The following is a description of a gene set: A change in the morphology or behavior of a leukocyte resulting from exposure to an activating factor such as a cellular or soluble ligand, leading to the initiation or perpetuation of an inflammatory response. Mouse Gene Set: GOBP_LEUKOCYTE_ACTIVATION_INVOLVED_IN_INFLAMMATORY_RESPONSE studied in species Mus musculus, and this is the list of marker genes: App, Jun, Casp1, Kcnn4, Snca, Cst7, Pparg, Cx3cl1, Clu, Kcnj8, Tlr9, Trem2, Csf1r, Sphk1, Mmp8, Itgam, Trpv1, Enpp1, Ctsc, Hspa4, Grn, Atm, Tlr6, Il13, Aif1, Ager, Tafa3, Ttbk1, C5ar1 (NCBI Gene Id 12273), Tlr4, Myd88, C1qa, Ifng, Nampt, Cx3cr1, Ifngr1 (NCBI Gene Id 15979), Tnf, Jak2, Mir7116, Tlr3, Calhm2 (NCBI Gene Id 72691), Stap1, Tlr2, Tlr1, Ldlr, Syt11 (synaptotagmin XI), Traf3ip2, Scnn1b, Naglu, Tyrobp, Il4, Il33, Lrrk2, Ifngr2, Nr1d1